The following is a description of a gene set: Any process that modulates the frequency, rate or extent of dendrite extension. studied in species Mus musculus Mouse Gene Set: GOBP_REGULATION_OF_DENDRITE_EXTENSION, and this is the list of marker genes: Cacng7 (NCBI Gene Id 81904), Ostn, Sh3glb1, Slc23a2, Mul1, Hnrnpk, Wnt5a, Rasal1, Cxcr4, Syt1, Afdn, Itsn2, Mecp2, Pten, Bcl11a, Syt2, Prkn, Unc13a (unc-13 homolog A), Nedd4l, Smurf1, Rims1 (NCBI Gene Id 77473), Spag9, Atg16l1, Plaa, Picalm, Cpne6, Syt3, Rnf157, Rims2, Cpne5, Syt4, Syt17, Reg1, Cpne9